The following is a description of a gene set: species: Homo sapiens Genes up-regulated in hepatoblastoma (HB) tumors as compared with non-tumor (NT) adjacent tissue. Background & Aims: Hepatoblastoma (HB) is a rare disease. Nevertheless, it is the predominant pediatric liver cancer, with limited therapeutic options for patients with aggressive tumors. Herein, we aimed to uncover the mechanisms of HB pathobiology and to identify new biomarkers and therapeutic targets in a move towards precision medicine for patients with advanced HB.<br/>Methods: We performed a comprehensive genomic, transcriptomic and epigenomic characterization of 159 clinically annotated samples from 113 patients with HB, using high-throughput technologies.<br/>Results: We discovered a widespread epigenetic footprint of HB that includes hyperediting of the tumor suppressor BLCAP concomitant with a genome-wide dysregulation of RNA editing and the overexpression of mainly non-coding genes of the oncogenic 14q32 DLK1-DIO3 locus. By unsupervised analysis, we identified 2 epigenomic clusters (Epi-CA, Epi-CB) with distinct degrees of DNA hypomethylation and CpG island hypermethylation that are associated with the C1/C2/C2B transcriptomic subtypes. Based on these findings, we defined the first molecular risk stratification of HB (MRS-HB), which encompasses 3 main prognostic categories and improves the current clinical risk stratification approach. The MRS-3 category (28%), defined by strong 14q32 locus expression and Epi-CB methylation features, was characterized by CTNNB1 and NFE2L2 mutations, a progenitor-like phenotype and clinical aggressiveness. Finally, we identified choline kinase alpha as a promising therapeutic target for intermediate and high-risk HBs, as its inhibition in HB cell lines and patient-derived xenografts strongly abrogated tumor growth.<br/>Conclusions: These findings provide a detailed insight into the molecular features of HB and could be used to improve current clinical stratification approaches and to develop treatments for patients with HB. Human Gene Set: CARRILLOREIXACH_HEPATOBLASTOMA_VS_NORMAL_UP from publication Carrillo-Reixach J, Torrens L, Simon-Coma M, Royo L, Domingo-Sàbat M, Abril-Fornaguera J, Akers N, Sala M, Ragull S, Arnal M, Villalmanzo N, Cairo S, Villanueva A, Kappler R, Garrido M, Guerra L, Sábado C, Guillén G, Mallo M, Piñeyro D, Vázquez-Vitali M, Kuchuk O, Mateos ME, Ramírez G, Santamaría ML, Mozo Y, Soriano A, Grotzer M, Branchereau S, de Andoin NG, López-Ibor B, López-Almaraz R, Salinas JA, Torres B, Hernández F, Uriz JJ, Fabre M, Blanco J, Paris C, Bajčiová V, Laureys G, Masnou H, Clos A, Belendez C, Guettier C, Sumoy L, Planas R, Jordà M, Nonell L, Czauderna P, Morland B, Sia D, Losic B, Buendia MA, Sarrias MR, Llovet JM, Armengol C (PMID 32240714), and this is the list of marker genes: KCP, TPR, DCAF7, ATP13A2, FRMPD2, CACNB4, SRARP, RPL6, IGF2BP2, H4C8, ZNF385C, NPTX1, ELK3, TEAD2, TP53BP1, RPS20, HTR1D, SEMA4F, LFNG, TRPC6, RPL18A, RAMP2-AS1, AACS, SH3RF3, TRIM16, CBX2, CCT3, NDRG1, NUP93, TIGD1, HOXA3, ILF2, TMEM94, TMEM67, PRKCQ, USP21, WNT6, CACNA2D3, GLG1, TMED3, BSG, IGHV7-81, LAMA4, TSPAN18, TNFRSF4, C6orf58 (chromosome 6 open reading frame 58), LPCAT1, RPA1 (NCBI Gene Id 6117), DOK1, FER1L4, RHOBTB2, OLFML2B, RPS7, TRIM59, UBE2Q2, HDAC7, DLX2, SYN3, HFM1, RIMKLA, CHST6, DLX6, MGAT5, TNFRSF19, FDCSP, LIX1, RPGRIP1L, FER1L6, GPR161, FAM83D, DLK1, SRC, HES2, PKM, UNC119B, NBEAP2, CLUL1, SNORD113-3, GABRD, TOR3A, ACAN, MDFI, MNX1, CREB3L2, CHRFAM7A, TRIM65, ZNF738, EPHB2, IRAK1BP1, SLC7A6, BTN2A3P, DIPK2B, PDE7A, PIAS3, WDR35, FRMD3, ATP6V0E2-AS1, PGAP4 (NCBI Gene Id 84302), PRTG, DGKD, MIXL1, ERCC6L, SPAG6, CHD3, RTKN2 (NCBI Gene Id 254060), CUL7, RNF144A, EPHX4, EIF3L, ZNF431, DLG5, FAM117B, PAQR8, PARPBP, GPC2, CASC15, NCAPD2, DNAJC18, GDPD1, BFSP1, WFS1 (wolframin ER transmembrane glycoprotein), EXTL3, SFTA1P, TP53I3, RBP7, OSBPL3, IGDCC4, SLC6A7, RAD21, DIO2, UBAP2L, SNORD114-13, CTHRC1, FOXS1, ATP6V0D2, TTLL1, HIP1 (NCBI Gene Id 3092), SUSD1, SLC25A35, IFT56 (intraflagellar transport 56), MMP11, SPOCK1, FANCB, RNFT2, SPATS2, NRBP1, LMX1B, NXPH3, TFAP2E, SV2A, RCOR2, CELSR3, MAP1B, SMC2, PTPDC1, SLC30A3, TBX2, KCNE3, APLN, STEAP1B, OSBPL7, PRND, SMYD3, MPZL1, RPSA, TICRR, CDH13, ZDHHC20, PEG3, ECT2, RPL23A, PRDM16, ENTREP3, ARHGEF3, UXS1, CDCA7, STXBP1, HASPIN, OLR1, CLIC1, MTFR2, NAT8L, HSPG2, CKAP2, NT5DC2, MTX1LP, RPL8, SLC6A9, TOMM20, DNM1P46, PKP1, TMEM178B, PDGFRB, DYNC1H1, EHMT2, CALU (NCBI Gene Id 813), EXTL1, SNORD114-3, DNMT3A, EBF2, KCNN3, HAS2-AS1, CST2, CPD, SLC6A8, BUB1, ZMYM3, LINC01011, C5orf34, CBX6, INPP5J, CACNA1I, ZNF610, STK39, MARCKSL1, C12orf75, RPS3AP46, DNM1P47, NOX4, NUDT4, GDF11, ZC3HAV1L, CIP2A, RPS4X, NKAIN4 (NCBI Gene Id 128414), AMPD3, FAM182B, RPL3, ITGA6, ZNF704, DVL2, GAS5, FGD1, RASAL2-AS1, CSN2, SORT1, CPLX2, ANKRD52, C15orf39, ZNF853, TMC2, SPDL1, LOXL3, LINC00205, LYZ, HSF2, BCAS4 (breast carcinoma amplified sequence 4), DNMT3B, RPS23, LINC00511, N4BP3, DLX3, IVNS1ABP, FUT2, BCAM, DOCK3, RBM20, DDX11-AS1, ZIM2, EIF3E, CENPF, ACLY, ISM2, PDGFA, SLC26A6, ERP27, MIR559, RPL9, RPS3, SYT15, ELP1, PCSK5, CENPL, RPL10A, RNF182, PRR11, ZNF775, PRKDC, STXBP4, KCTD7, ATP1A4, TRIM24, RAN, HDAC11, MTBP, GREB1, PFN4, PDE4C, SUPT3H, PRDM16-DT, MAP4K4, HSDL1, SCN5A, MIR656, NAP1L1, MSX1, BIRC7, SH3PXD2B, BLM, EPHA4 (EPH receptor A4), ADAM9, CDCA4, COL4A1, EFNA3, G6PD, PPP1R14C, UACA, PTP4A3, BEND5, DLX4, ATP8B2, LY6H, BMP4, CCR6, DLX6-AS1 (DLX6 antisense RNA 1), GSN, DPY19L2P2, PLVAP, OLIG3, ACBD7, MIR770, CHIT1, COMP, CNMD, HCAR1, ZNF66, WDR76, CCDC88C, LRRC37A17P, SLC7A10, MECOM, ITGAE, FMNL2, HIF1AN, SLC1A5, CTSV, EEF1A1, HSP90AB1, NKD1, CCDC102B, R3HDM1, CDH24, ZNF792, RPL5, RNF157, SIX1, PFKFB4, RPS5, ELAPOR1 (endosome-lysosome associated apoptosis and autophagy regulator 1), IPO9, MIR493HG, SGO2, RAVER2, TMSB15A, CARM1P1, ENTPD1, H2BC17, USP51, MAMSTR, B3GALNT1, GJB6, IL31RA, RHPN1, COL9A3, ZNF391, JARID2, COL4A2, TBC1D16, ROBO1, INKA2-AS1, MSH2, SERPINE2, CCDC88A, CEP250, PLCG1, COLEC12, FMNL3, TRIP13, NOS2, OXCT1-AS1, SEMA3G, LINC01091, BIK, CIZ1, ARHGEF2, GBX2, MEG3, TNFSF4, TRPC1, HMGB2, RNASEH2B-AS1, SAMD13, COL1A2, CCDC85A (NCBI Gene Id 114800), CA8 (NCBI Gene Id 767), RPL28, CEP68, LINGO1, LPCAT4, ZNF70, RPL4, EDARADD, FAM3B, AP3M2, FIRRM, CDKN2B-AS1, ASAP2, STMN1, NETO2, MATN3, LUZP2, CAPN11, SRRM3, TCTN2, NTM, USP46, SMTNL2, ZCCHC12, EFNA4, MYOZ3, CALM3, IGDCC3, RPL23, PFAS, EFR3B, ANAPC1, KIF18A, CRNDE, RASL11B, PACC1, RASD2, MCM6, PRC1, EPB41L2, ZNF286A-TBC1D26, UTRN, ZNF385A, DLL4, CDX1, POU2AF3, NPM1, SLC7A11, RPS11, SMYD2, ZBTB12, IGHVII-78-1, CTSC, MFGE8, GPC3 (NCBI Gene Id 6394), BICD1, ZNF273, LRP8, COL7A1, ZNF286B, REEP4, QPCT, RTL1, LLGL1, NECTIN1, KAZALD1, RPL23AP7 (ribosomal protein L23a pseudogene 7), CEP152, GNAS, RHOBTB1, JCAD, VAT1, LMNB2, ATP10D, CASKIN1, LOXL1-AS1, B3GNT5, ZNF107, CCNF, ARL6IP6, TARBP1, MAPK13, KLHL30, RPL7, ABCB9, INSYN1 (NCBI Gene Id 388135), GNAL, RPL35A, RASL12, KIF2A, BCL11A, E2F7, SERPINI1, TLCD5, RPS12, DNM3, FOXJ1 (NCBI Gene Id 2302), CPA5, NPNT, RFX7, APBA2, ZNF74, LIN9, MIS18BP1 (NCBI Gene Id 55320), PROCA1, BCYRN1, CBX5, NCSTN, RPS27A, NUAK1, MAGED2, CDK6, ASCL2, SEPTIN2, MDK, PTK2, EIF4B, PARVB, PART1, TBKBP1, VIM, RPL13, GRAMD1A, TUBA1B, MMS22L, CDK4, PABPC1, GNA12, RPS6, AKR1B1, LEF1-AS1, GNG4, SMARCA4, CSE1L, ATP6V1B1, HOXC4, LAMA3, TMEM182, SALL2, CENPE, CTNNB1, PTPN5, FGF20, SNRNP200, MCM8, TACC1, RNASE1, CKAP4, PEA15, HSP90AA1, BOLA3-DT, PIK3R2, SCAMP5, TMEM98, MEG9, ZNF695, LAMB4, HEATR1, TMEM237, KIAA1549, EPCAM, CENPQ, RCN2, SIX4, HNRNPA1, SLC6A6, EEF2, PYGB, GAREM2, PARD3B, ZNF572, SQLE, TMC7, IFT52, PTGES3L, NDRG3, MYCN, JRK, TM4SF19-AS1, MINAR1, KCNJ5, SMARCC1, OLFML2A, INKA2, HDAC2, PRRG3, SP6, P4HA2, SNORD114-28, UGGT1, TMEM52B, SH3BP1, HTR1F (NCBI Gene Id 3355), SNHG32, CD34, IRX5, TAF6, ITM2C, TRAIP, SYT11, ZNF703, PTPN14, CDKN2A, TIA1, DKK1, B3GNT8, LEF1, SLC39A10, RPS27, SNORD113-4, YEATS2, SANBR, TET1, MTR, PLXND1, TRIM28, NDN, WDHD1, KIF7, GADL1, PIP5K1B, SLC45A4, IMPDH2, RPS3A, CCNI2, PCDHGA1, ELOVL4 (ELOVL fatty acid elongase 4), RPL19, ZNF519 (zinc finger protein 519), PBXIP1, ALOX15B, ASCL5, ESM1, DQX1, MZT1, TBX4, ADAMTS6, NDRG4, SHROOM4, GPD1L, RAB39B, CREG2, PTK7, MTCL3, AXIN2, CPA6, MTCL2, TCF3, DGKI, ANKRD27, ATN1 (atrophin 1), PFKM, ATP10A, GASK1B, PAPSS1, BMF, CBX1, FGF13-AS1, CHGB, PIK3C2B, PGAP1, RPL31, DRP2, SEPTIN8, SEPTIN3, NES, LINC02875, SPACA9, ZFP37, SLC26A2, OXCT1, PASK, RPL10, PRUNE1, ADCY6, BLMH, SLC25A36, FRRS1L, NRP2, LAMB1, KIT, SCG2, PLD3, DSC3, SNORD114-10, DUSP26, OR51E1, STOX1, CRTAP, MVB12B, LZTS2, RPL7A, USP22, DDAH2, ODAM, FOXF2, RPS19, KRBA1, SHCBP1, CFAP300, ZNF781, CUEDC1, LAPTM4B, CCND2, ALOX12B, LINC00327, CTNNA2, VAX2, COPG2, MILIP, RPS2, GAS2L3, MFAP2, MYH10, RBL1, ITGA2, PTPRG, FRAS1, ZNF14, NRXN3, SLC6A4, BCAT1, CA5B, PNMA8A, DBN1, RERE, THBS4, HNRNPA3, FANCE, ERVMER34-1, KLHL38, JAG2, BORA, CCN3, RASAL2, EML6, FAM217B, EID2B, SIX2, GDPD2, RNF24, NOTCH3, CACNA1S, ZNF607, H2AC25, FERMT1, RACK1, TTYH3, TRIB2, ZNF730, RAB34 (NCBI Gene Id 83871), CACNA1B, ZNF883, RPL37A, ZNF714, GPX7, SLC38A5, ARHGEF11 (Rho guanine nucleotide exchange factor 11), LDB1, STRA6, PODXL, NSMAF, LAMC1, HSPA12B, MGAT3, TGFB2, MEAK7, RHPN1-AS1, RASGRF1, SLC4A8, SPINDOC, ADAMTS18, DHX57, SELENON, INCENP, ASIC1, PCDHGB2, ILF3, ASAP1, B3GALT1, MTMR2, REEP2, ABRAXAS1, ANKRD65, GLS, ADAM32, ENAH, ZNF788P (zinc finger family member 788, pseudogene), FAM72A, ZFP69B (ZFP69 zinc finger protein B), FOXO3B, SCIN, C18orf54, KCNH6, KIF15, LINC02210, MTA3 (NCBI Gene Id 731342), ADRA2C, KDM5B, DLX5, PNMA1, MAGED1 (NCBI Gene Id 9500), RHNO1, LIMK1, RPSAP52, SNORD114-1, XXYLT1, AK8, AP2B1, DISC1, SACS, PRKG1-AS1, INPP5D, ZNF711, CPNE1, EDN3, TSPAN5 (tetraspanin 5), FSD1L, DYNC1I1, SINHCAF, CROCCP3, KIF3A, RPLP0, CLSTN1, FABP5, SLC1A3, RFX6, CHST10, FLVCR1, ARMC9, PDZD7, AJAP1, ZNF280A, YWHAZP4, FKBP10, RPL27, VASH2, CCDC102A, DLG3, NPTXR, C4orf46, CENPI, PKN1, RACGAP1, GRIK4, CHRNA1, SDK1, RPS8, VCAN, EMC3-AS1, HOXA-AS2, ABCC5, DPF1, RPL13A, TMCC1-DT, CORIN, PPT1, PLXNA1, RPS18, TRIM71, PLAG1, KSR1, CLDN11, COL15A1, TMEM132A, ASIC2, TRIM46, STC2, TRIM17, KIF4A, PLXNC1, CLIP2, LRP4, MYO1D, AFAP1L1, FOXL1 (NCBI Gene Id 2300), ZNF660, CEP55, ZBTB40, RFX3 (NCBI Gene Id 5991), PCYOX1L, CDK5R1 (NCBI Gene Id 8851), PAX2, HMGA2, RHBDL3, ENSG00000187951 (novel transcript), MYLK-AS1, AIF1L, ARID3A, ZNF287, MIMT1, MCTP1, MAGEE1, GXYLT2, GSDME, RPL12, RIBC2